Given this list of marker genes FZD6, WIF1, FOXN1, GAPDH, EP300, ACTB, WNT7B, WNT6, PORCN, AXIN1, WNT9A, WNT3, FBXW11, CCND2, FBXW2, LRP5, NLK, DKK1, GSK3B, WNT1, SOX17, FRAT1, CCND3, CSNK2A1, TCF7L1, TLE1, CSNK1D, TLE2, FGF4, WNT2, WNT7A (Wnt family member 7A), WNT11, LEF1, CSNK1A1, MYC, WNT4, BCL9, CCND1, PPP2CA, WNT10A (NCBI Gene Id 93651), WNT5B, KREMEN1, CSNK1G1, CTNNBIP1, WNT2B, TBXT, FBXW4, SFRP1, LRP6, FZD4, CXXC4, HPRT1, TCF7, CCN4, WNT16, PITX2, DVL1, DVL2, JUN (NCBI Gene Id 3725), PYGO1, BTRC, DAAM1, DIXDC1, FOSL1, SENP2, FZD3, WNT8A, TLE5, NHERF1, RHOU, WNT5A, FZD7, FRZB, CTNNB1, B2M, FZD5, CTBP2, WNT3A, FZD8, FSHB, GSK3A, CTBP1, FZD2, FZD1, SFRP4, RPL13A, APC, PPP2R1A, NKD1, here is a description of the gene set: studied in species Homo sapiens Genes related to Wnt-mediated signal transduction Human Gene Set: WNT_SIGNALING